Given this list of marker genes CD2, SH3BP5, CLEC4E, KIF22, ITGB7, MDM4, PGGHG, DCPS, SERPING1, ACKR3, ZAP70, MVP, SAMHD1, APOL2, ICAM3 (NCBI Gene Id 3385), SP140L, APOL6, TEX14, CHMP7, GPR65, GARRE1, ABCG1, ALOX5AP, IRF1, MCUB, CXCL11, NUP210, ATP8A1, CXCL5, SERPINA1, TNFSF10, GIMAP4, LIMK2, CLEC2B, PRKD2, LPAR2, RBM10 (RNA binding motif protein 10), UBA7, BIN2, IRF7 (interferon regulatory factor 7), TCF7, IFITM2, MYD88, SOD2, HLA-J, FKBP11, CHRNB1 (cholinergic receptor nicotinic beta 1 subunit), STAT5A, CHI3L2 (chitinase 3 like 2), IDO1, IL16, TMEM109, TSC22D1, SQOR, PSMB10, VNN1, GK, CALCOCO2, KIF16B, GBP1, YIPF1, CSTF2T, PPBP, PRKCZ, WWC3, CBLL1, SERPINB2, RNFT2, IL1A, GNG11, PIM1, DDX56, BCL2A1, APBA2, GK3 (glycerol kinase 3), SLAMF7, CARS2, IL15, LGALS3BP, BTN2A1, FAM117A, SLC14A1, LILRA1, ADAMDEC1, INHBA, IL11RA, GIMAP5, GCH1, RPS6KA3, TAP1, FCGR1BP, SP110, PDCD2, TKTL1, SMARCA4, SRRT, PTPRCAP, C3, IFITM3, RABGAP1L, DHX58, KIAA0586, SNX10, CD6, NOSIP, UBE2L6, TNFAIP6, WARS1, HERC5, NME7, ADM, STOM, LPIN1, MX2, IFI44L, BTN3A3, TLR8 (toll like receptor 8), CYBB, SUN2, TXNL4B, SMCO4, CSGALNACT1, CCR2, P2RY6, LTB, ITPR1, APOL1, IFITM1, AIM2, ECSIT, DUSP21, EPHX2, HAUS7, ALDH2, CXCL8, ANK3, CXCL1, CHI3L1, SPOCK2, HDDC2 (NCBI Gene Id 51020), LAT2, PLAAT4, PMM1, TMCO6, APOL3, VAMP5, CCL2, THBS1, EHD1, CCDC69, UXT, FCMR, CCL7, CASP1, TYMP, FOXO1, STAT1, PVRIG, CXCL9, ISG15, CD38, MAGOH2P, NAP1L4 (NCBI Gene Id 4676), KANK1, SP140, GPR161, SP100, CFLAR, PMP22, VSIG4, EGR4, GVINP1 (GTPase, very large interferon inducible pseudogene 1), CLUAP1, GNAT1 (G protein subunit alpha transducin 1), TRIM21, ASNS, RBCK1, ARMT1, PLXNC1, IL15RA, DDIT3, MAN1C1, CXCL3, UBE2D1, IFIT3, SELL, CXCL10, DUSP6, PARP12, GBP2, PSMB9, HK2, RPL36, CKAP4, RASGRP2, PSMB3, RGS3, CD40, ACTN1, POLI, here is a description of the gene set: Human Gene Set: GSE24634_IL4_VS_CTRL_TREATED_NAIVE_CD4_TCELL_DAY3_DN CD25+ regulatory T cells develop in the thymus (nTregs), but may also be generated in the periphery upon stimulation of naive CD4 T cells under appropriate conditions (iTregs). The mechanisms that regulate the generation of peripheral iTregs are largely unknown. We used microarrays to gain insights into the molecular program of extrathymic Treg development. studied in species Homo sapiens Genes down-regulated in comparison of CD25- T cells treated with IL4 at day 3 versus untreated CD25- T cells at day 3. from publication Prots I, Skapenko A, Lipsky PE, Schulze-Koops H (PMID 21347372)